The following is a description of a gene set: studied in species Homo sapiens A type of cataract with punctate opacities of the lens. Punctate cataract Human Gene Set: HP_PUNCTATE_CATARACT, and this is the list of marker genes: GJA5 (gap junction protein alpha 5), VIM, BEST1, OPA3, FTL, CRYGC, LIM2, CRYBB1, GJA8, HSF4, CRYBB2, RTN4IP1, MAF, SEC23A